Given this list of marker genes MRC2, PPP1R18, REST, COLGALT1, NHSL2, MYOF, KANK2, CYTOR, CHSY1, SYDE1, ACTN1, POSTN, PLOD2, COL8A1, GPX7, PGD, AHNAK, MYL12A, EIF2S3, RCC2, MFAP4, MYLK, SERPINH1, ETS1, PGAM1, GAS7, ADH5 (NCBI Gene Id 2223), COL4A2, BASP1, STC1, MXRA8, DLC1, SASH1, FGF7, RAB31, PTMA, ARPC1B, MAP1A, RPLP1, HYCC1, HCLS1, WIPI1, FAM114A1, RASSF8, KCNE4, VMP1 (NCBI Gene Id 81671, vacuole membrane protein 1), PABPC1, FHL2 (four and a half LIM domains 2), SH3PXD2A, ITGA5 (integrin subunit alpha 5), TBC1D16, P3H4, FSCN1 (NCBI Gene Id 6624), MFGE8, MYO10, GAPDH, NPM1, LDHA, WLS, NOTCH3, TNKS1BP1, MARS1, IL6, RPL27, LUM, C11orf96, FEZ2, TALDO1, VSTM4, SYNCRIP, PRDX6, IL1R1, MAX, HTRA1, CD276, PHLDA1, CTDSP2, CAVIN3, ATF4, MANF, EIF2S2, COL15A1, CEMIP, TUBB6, ANO6 (anoctamin 6), ARHGEF17 (NCBI Gene Id 9828), TMEM165 (transmembrane protein 165), MARCKS, CDR2L (cerebellar degeneration related protein 2 like), EPS8, CDK4, PMP22, HAPSTR1, TMSB4X, TMEM50A, LHFPL2, TFPI2, MAPKAPK2, FLNA (filamin A), ITGB3, SHMT2, NUPR1, HTRA3, SPRED1, SAR1A (NCBI Gene Id 56909), PDE3A, PLAU, RASAL2, MYC, ADAMTS2, CAP1, OXA1L (OXA1L mitochondrial inner membrane protein), MTHFD2, TMED9, WWTR1, SFRP2, EMP1, SSH1, COL3A1 (NCBI Gene Id 1281), BMP8A (bone morphogenetic protein 8a), SULF2, TMEM214, LTBP2 (NCBI Gene Id 83981), SLC4A7, GREM1, RSL24D1, PABPC4, KANK4, YARS1, CTNNB1, MMP9, VCAN, CALD1, POMP, ZNF469, SRPX2, AKAP12, LMNA, RND3, EEF1A1, SSC5D, LMO4, ANKRD11, HIC1, RASL12, ASNS, PAPPA, CFL1, LATS2 (NCBI Gene Id 95108), LAMA4, GASK1B, KCTD10, TARS1, HSD11B1, ABHD4, ATF5, PIEZO2, DUSP5, KCNG1, CCN4, ARID5B, ADAM19, KLF9, RAN, ANXA5, TNFAIP6, IL4R, ACVR1, JARID2, FGF2, TXN, CEP170, MIR100HG, YIPF5, GALNT10, A2M, RHOQ, TRAM2, NKD1, TGFB3, MCC, S100A11, FBXO32, ARHGAP21, TIMP1, LOX, G0S2, CCN2, ARF4, AKAP13, TGFBR1, NR3C1, LRRC32, TMEM204, LHFPL6, SPATS2L, JAM3, MAP4, EXT1, HDAC7, MAP4K4 (mitogen-activated protein kinase kinase kinase kinase 4), COL6A3, TFPI, ADGRA2, IFI16, RNF168, TMTC3, MYH9, PMEPA1, FRMD6, S100A16, NOTCH1, AEBP1, ITPRIP, STON1, ZEB1, AHR, QKI, NRP2, UACA, GPX8, C1R, STK24, TBX2, ITGB5, FHOD1, ADAM12, IGFBP5 (insulin like growth factor binding protein 5), MPZL1, PLIN2, PDGFRA, LGALS1, SH3PXD2B, COL12A1, CLIC4 (NCBI Gene Id 25932), TNS3, CCDC71L, MEDAG, PRDX1, MSN, CYGB, HNRNPAB, TXNRD1, SPART, RB1CC1, HMCN1, RFTN1, RNF24, COL5A1 (NCBI Gene Id 1289), TCF4, ENC1, LITAF, PLS3, EIF3M, CAPZB (capping actin protein of muscle Z-line subunit beta), CD59, NREP, HDLBP, CD248, PSAT1, PLXDC1 (NCBI Gene Id 57125), PXDN, REXO2, GNB4, RCN2, C2CD2, IER3, IFITM3, TGM2, C1S, LAMB1, OSMR, RSU1, CD82, HMGB1, RIC8A, FNDC3B, PDGFRB, CDK2AP1, STEAP1 (STEAP family member 1), TUBB, FAT1, SH3KBP1 (SH3 domain containing kinase binding protein 1), FYN, TPM2, CTHRC1, TPST1, AXL, YBX1, IFITM1, GPC6, FTH1P3, C3orf80, PTGES, AP2M1, ARHGEF2, CKAP4, IRX4, ANXA1, MGP, SERPINE1, LTBP1, CREB3L1, RPS16, JAK1, INHBA, MAP3K20, RCN1, TMSB10, LRRC59, HK1, CTSC, SLC25A3, OSTC, TPM4, AMOTL1, CCDC102B, UNC5B, GYPC (glycophorin C (Gerbich blood group)), TTYH3, IL11, SEC31A, ANXA2P2, SNHG5, SEC23A, RAB23, EEF1D, SERPINF1 (NCBI Gene Id 5176), CCDC74A, NID2, FKBP11, ZEB2, EDNRA, ACTB, ALDH1L2 (NCBI Gene Id 160428), COL4A1, ARHGEF40, SKIL, BZW1, NAV1, TPM1, EBF1, TMEM47, PLSCR4, ZCCHC24, MSX1, CSGALNACT2 (NCBI Gene Id 55454), CTSB (cathepsin B), HBEGF, ADA, PEA15, RCAN1, ZYX, COL6A1, TKT, SLC44A1, NEXN, PAG1, TMEM98, HAS2 (NCBI Gene Id 3037), CYP1B1, ITGB1BP1, PRDM1 (PR/SET domain 1), VDR, IARS1, ITGA1, HSPA5, MYADM, BPGM, NQO1, EFNB2, EPRS1, PTPN14, MICAL2, PABPC3, LIMS1, ID3, PTGS1, ACTR3, TRIB3, ITGAV, TPI1 (triosephosphate isomerase 1), BHLHE40, HEG1, DCBLD2, CMTM3, RBMS1, RPL13A, YKT6, PTDSS1, RPL4, SEC24D, TNFRSF12A, SSR3, GNG11, RHBDF1 (rhomboid 5 homolog 1), TUBA1C, SHC1, COL1A2, RPL10A (NCBI Gene Id 4736), KITLG, PTPN12, SFRP1, MTDH (metadherin), HNRNPA1L2, CHST15 (carbohydrate sulfotransferase 15), PLAT, ACSL4, SPON1, F2RL2, MIR4435-2HG, NAP1L1, RFLNB, LACC1, VCL, CTSL, SCARA3, SUSD2, ANGPTL4, FADS1, SACS, THBS1, TRIO (NCBI Gene Id 7204), FKBP9 (FKBP prolyl isomerase 9), TBX3, CYTH3, MT2A, CALU, DDIT4, FBN1, WBP1L (NCBI Gene Id 54909), ZNF281, DUSP6, GSTO1, EEF2 (eukaryotic translation elongation factor 2), PLOD1, PTK7, COL5A3, SRM, GEM, PARVA, DIMT1, SPARC, SPON2, IL33, LAMC1, GPNMB, THY1, MMP1, ITGA11, WIPF1, NID1, RAI14, AFAP1, B4GALT1, GJD3, SRXN1, NR2F2, MRAS, SDC2, PCK2, RAB32, RPL10, TGFB1I1, LIF (LIF interleukin 6 family cytokine), PRKG1, RPL23, OAT, CRLF1, DYRK2, GOLIM4, RGS10, PELO, NHS, TPT1, CBS, SEC13, BGN, SPHK1, HOXB2, RPL39, FN1, SGCD, ATP1B3, CERCAM, DUSP14, COPS8, RPL22L1, MSC-AS1, CNN3, ACTA2, TWSG1, WNT5A, ISLR, IGFBP4, FERMT2, TIMP2, ANXA6, SNX9, IGFBP7, RUNX1, FAP, CARMN, MMP2, NCK2, KLF13, VIM, ANO1, SULF1 (sulfatase 1), CDH11, PHB2, CNN2, NRP1 (NCBI Gene Id 8829), MGST1, CCDC80, CAMSAP2, IGFBP3, BAZ1A, F2R, ENO1, ZBTB38, EHD2, CAVIN1, NT5E, TSPAN5, COL18A1, COL1A1, SPRED2, FMOD, LXN, SLC2A3, LAMC3, RPL10L, SVIL, TLN1, CCN1, NUMBL, LAMA2, SYNJ2, LAMP5, GOLT1B, RPS13, SH3BGRL3, BMP1, PHGDH, OLFML2A, WARS1, RBPMS, PPFIBP1, MYO1E, SPRY4, NDN, ARPC2, PRRX1, FARP1, SNAI1, SLC7A11, KPNA4, ZNF532, KDELR3 (KDEL endoplasmic reticulum protein retention receptor 3), RRAGA, PSMA7, S1PR3, COL5A2, DSE, PLEKHO1, FKBP10, COL16A1, STK17B, PEAK1 (NCBI Gene Id 79834), JCAD, PTPRE, PFN1, TMEM158, MMP11, HES1, CBR1, FMNL3, SPSB1, DACT1, CRTAP, IFITM2, DAB2, SH2B3, EPAS1, ENAH, IKBIP, SMC4, ANTXR1, ARL4C, ABCA1, DDX21, EIF3A, TNS1, PLAUR, NFIC, ARL8B, NNMT, PPIC, GALNT1, FIBIN, EID1, GFPT2, THBS2, PTGFRN, GLI2, WDR1 (NCBI Gene Id 9948), RBM3 (RNA binding motif protein 3), XPOT, RPLP0, TGFBI, RPS23, SLC38A2, FOXF2, ANXA2, ZFP36L1 (NCBI Gene Id 677), APEX1, NOTCH2, NES (NCBI Gene Id 79662), NIN, ATXN1, SNAI2, BTF3, COPA, ITPRIPL2, DEGS1, NPC2, H2AZ1, ITGB1, SLC1A5, CRISPLD2, TNC, MSANTD3, KDELR2, LOXL2, MARCKSL1, SNHG16, HEYL, CEBPB, ANGPTL2, YAP1, RACK1, LMCD1, JAG1, ITGA2, TPBG, NOTCH2NLA, SELENOS, SPOCK1, VASN, PHC2, TIMP3, DCN, COL6A2, MDFIC, TIMM17A, P4HA3, PTGS2, EDNRB, LDHB, CYBRD1, PHLDB1 (pleckstrin homology like domain family B member 1), CAV1, ARHGAP23, ACTG1, RLIM, RAP1B, ADAMTS4, FSTL1, STK38L, MCL1, GARS1, EEF1B2, ROCK2, G6PD (glucose-6-phosphate dehydrogenase), CBX3, GUCY1A2, CBLB, SMIM3, CTSK, DKK3, here is a description of the gene set: Human Gene Set: MURARO_PANCREAS_MESENCHYMAL_STROMAL_CELL from publication Muraro MJ, Dharmadhikari G, Grün D, Groen N, Dielen T, Jansen E, van Gurp L, Engelse MA, Carlotti F, de Koning EJ, van Oudenaarden A (PMID 27693023) species: Homo sapiens